Given this list of marker genes Ssx2ip (NCBI Gene Id 99829), Sh2d4b, Parp11, Csdc2, Zkscan1, Snx8, Nadk, Wdr26, here is a description of the gene set: Mouse Gene Set: XIE_TRASTUZUMAB_CARDIOTOXICITY_MMU_MIR_690_GENES studied in species Mus musculus Abstract: Trastuzumab-induced cardiotoxicity (TIC) is a common and serious disease with abnormal cardiac function. Accumulating evidence has indicated certain non-coding RNAs (ncRNAs), functioning as competing endogenous RNAs (ceRNAs), impacting the progression of cardiovascular diseases. Nonetheless, the specific involvement of ncRNA-mediated ceRNA regulatory mechanisms in TIC remains elusive. The present research aims to comprehensively investigate changes in the expressions of all ncRNA using whole-transcriptome RNA sequencing. The sequencing analysis unveiled significant dysregulation, identifying a total of 43 circular RNAs (circRNAs), 270 long noncoding RNAs (lncRNAs), 12 microRNAs (miRNAs), and 4131 mRNAs in trastuzumab-treated mouse hearts. Subsequently, circRNA-based ceRNA networks consisting of 82 nodes and 91 edges, as well as lncRNA-based ceRNA networks comprising 111 nodes and 112 edges, were constructed. Using the CytoNCA plugin, pivotal genes - miR-31-5p and miR-644-5p - were identified within these networks, exhibiting potential relevance in TIC treatment. Additionally, KEGG and GO analyses were conducted to explore the functional pathways associated with the genes within the ceRNA networks. The outcomes of the predicted ceRNAs and bioinformatics analyses elucidated the plausible involvement of ncRNAs in TIC pathogenesis. This insight contributes to a better understanding of underlying mechanisms and aids in identifying promising targets for effective prevention and treatment strategies. from publication Xie S, Zhou N, Su N, Xiao Z, Wei S, Yang Y, Liu J, Li W, Zhang B (PMID 38577019)